Given this list of marker genes TIFA, IGHV5-78, RABGAP1, BCAR3, PCBP2, UBE2C, UBAP2, RNFT2, EIF2D, GPER1, ITGB1, TXNDC16, MRPS27, PRPF38A, C2orf88, UHRF1, SLBP, PXMP4, RSU1, PMS2P11, LMO2, GRHPR, USP32P2, PANK1, ZNG1A (NCBI Gene Id 57397), SLC2A5, CUL3, RFX7, VRK1, GABPB1, TYMS, KCTD9, TCL6, AAMP, LHFPL6, ESPL1, H2AZ1, POU2AF1, NPR2, SERPINA9, MND1, BUB1B, FHOD3, ARL2BP, CDCA7, GCSAM, ENPP3, BTF3, AK3, PRDX3, CALM2, ABHD8, SMARCB1, CTTN, DPY19L2, FBXO5, RAD21, GINS1, PSMD10, GRPEL2, MCRS1, MCM4, SUGCT, CLIC4, BIK, CD81, LINC00487 (long intergenic non-protein coding RNA 487), RAD54L, HSPA2, MCM2, CDCA5, ZFAND4, GMCL1, NAA38, ATP6V1A, MET, ANP32E, CCNE1, ASPH, TERF2IP, HNRNPD, MPHOSPH9 (NCBI Gene Id 64797), CENPE, GSTA4, PLK1, PEG10, CDCA4, GAPDH, HSBP1, GINS3, ASF1B, VEZT, PARN, PRPSAP2, RPA1, SLCO3A1, UBR5, HELLS, PCNA, KANK2, NCAPD3, EIPR1, SOX9, DHFR, CKAP5, CIDEA, ANP32B, RBM17, HES6, DAAM1, UBE2G1, ZW10 (zw10 kinetochore protein), ROMO1, PITPNC1, NDC1, DENND1B, EDRF1, KPNA2, SYNE2, LMCD1, KCNN3, ZNF141, FBXO30, NDUFA12, CHIC2, NSD2, ACTR2, SRP9 (signal recognition particle 9), TOP1, H2AX, RAB30-DT, DTL, EXOSC1, RFC4, MASTL, PSIP1, CASP3, MCM3, PRKDC, SAMHD1, BAIAP2L1, RNGTT, TUBB3, YWHAE, LIMS1, BCL6, RAPGEF5, PRELID3B, MIXL1, CCDC167, ANAPC15, CEP152, SLC25A15, MYH10, GFPT1, SPRING1, EED, SMC2, CD38, NCAPG2, TNFSF8, OAZ1 (NCBI Gene Id 4946), SEC61B, HNRNPC, CCNB2, SYVN1, SEPTIN2, SEMA4A, TEC, FAM106A, TDP1, CHAMP1, PHF19, ASB13, AP3S2, MAP2, PLEK, AZIN1, ROCK2, PABPC4, SNX30, MBD2, GLRA1, CENPM, CHEK1, KIF22, HRK, GNA13, APOM, HMGN3, BCAS4, ARHGEF9, ZNF215, TMEM106C, ATP5MG (NCBI Gene Id 10632), MGST2, PFKM, KIF4A, here is a description of the gene set: Human Gene Set: GSE12366_GC_VS_NAIVE_BCELL_UP Sorted B cells using flow cytometry. CD19 selected B cells were sorted using flow cytometry. studied in species Homo sapiens from publication Longo NS, Lugar PL, Yavuz S, Zhang W, Krijger PH, Russ DE, Jima DD, Dave SS, Grammer AC, Lipsky PE (PMID 19023113) Genes up-regulated in comparison of germinal center B cells versus naive B cells.